The following is a description of a gene set: studied in species Mus musculus Any process that modulates the frequency, rate or extent of melanocyte differentiation. Mouse Gene Set: GOBP_REGULATION_OF_MELANOCYTE_DIFFERENTIATION, and this is the list of marker genes: Adamts20, Zeb2, Adamts9, Gnaq, Kitl, Gna11, Bcl2